The following is a description of a gene set: electronically inferred by orthology from the curated human pathway part of: Degradation of beta-catenin by the destruction complex This event has been computationally inferred from an event that has been demonstrated in another species.<p>The inference is based on the homology mapping from PANTHER. Briefly, reactions for which all involved PhysicalEntities (in input, output and catalyst) have a mapped orthologue/paralogue (for complexes at least 75% of components must have a mapping) are inferred to the other species. Reactome Pathway: Beta-catenin phosphorylation cascade studied in species Mus musculus, and this is the list of marker genes: Ppp2r5a, Ctnnb1, Frat1, Ppp2r5d, Amer1, Ppp2r1b, Axin1, Ppp2r5b, Csnk1a1, Frat2